Given this list of marker genes MAPK1, HGF, KRAS, SOS2, HRAS (NCBI Gene Id 338029), BRAF, MAP2K1, MAPK3 (NCBI Gene Id 5595), RAF1, MET, GRB2, MAP2K2, NRAS (NRAS proto-oncogene, GTPase), ARAF, SOS1, here is a description of the gene set: Pathway Definition from KEGG: HGF -> MET -> GRB2 -> SOS -> RAS -> RAF -> MEK -> ERK Human Gene Set: KEGG_MEDICUS_REFERENCE_HGF_MET_RAS_ERK_SIGNALING_PATHWAY HGF-MET-RAS-ERK signaling pathway. Pathway ID: N00216. Pathway type: Reference. Pathway class: nt06261 Gastric cancer. studied in species Homo sapiens